The following is a description of a gene set: Mouse Gene Set: GOBP_NEGATIVE_REGULATION_OF_RUFFLE_ASSEMBLY studied in species Mus musculus Any process that stops, prevents or reduces the frequency, rate or extent of ruffle assembly., and this is the list of marker genes: Kank1, Evl, Tacstd2, Arhgap24, Pfn2, Stap1 (signal transducing adaptor family member 1)